Given this list of marker genes Igf2bp2, Ythdc1, Ythdf1, Ythdc2, Rbm33, Igf2bp3, Hnrnpa2b1 (NCBI Gene Id 71605), Fmr1, Igf2bp1, Hnrnpc (heterogeneous nuclear ribonucleoprotein C), Ythdf3, Ythdf2, here is a description of the gene set: A protein adaptor that recognizes and binds an RNA molecule modified by N6-methyladenosine (m6A), a modification present at internal sites of mRNAs and some non-coding RNAs. Mouse Gene Set: GOMF_N6_METHYLADENOSINE_CONTAINING_RNA_READER_ACTIVITY studied in species Mus musculus